Given this list of marker genes ABCG8, ABCG5, here is a description of the gene set: ATP-binding cassette sub-family G member 5 (ABCG5 aka sterolin-1), is a "half transporter", that forms a complex with another half transporter ABCG8 (aka sterolin-2) in the endoplasmic reticulum. This complex translocates to the plasma membrane to mediate the ATP-dependent intestinal absorption and facilitation of biliary secretion of cholesterol and phytosterols (e.g. sitosterol). Defects in either of these half transporters result in loss of enterocyte discrimination between cholesterol and sitosterol causing sterol accumulation and predisposition for atherosclerosis. Defects in ABCG5 are the cause of sitosterolemia (MIM:210250), characterised by unrestricted intestinal absorption of both cholesterol and plant-derived sterols causing hypercholesterolemia and premature coronary atherosclerosis. Patients with sitosterolemia absorb between 15 and 60% of ingested sitosterol and excrete only a fraction of this into the bile. part of: ABC transporter disorders Reactome Pathway: Defective ABCG5 causes sitosterolemia studied in species Homo sapiens